Given this list of marker genes TP73, HMGB1, BCL2L11, DSG3, MAPK3, FADD, MAPT, PSMA7, LMNA, PSMD13, BAD, PSMB4, KPNA1, DIABLO, AKT3, ACIN1, UBC, BID, PSMB3, APPL1, CASP9, PSMB7, DAPK3 (NCBI Gene Id 1613), CFLAR, TP53BP2, DYNLL2, DCC (NCBI Gene Id 1630), GAS2, BCL2 (BCL2 apoptosis regulator), PSMD8, CYCS, APAF1, PSMD1, SATB1, PSMA3, TNFSF10, RIPK1, TICAM2, STAT3, PSMB5, XIAP, STK24, DFFA, SFN, PLEC, H1-3, PAK2, PKP1, PSMD14, CTNNB1, GSDMD, YWHAH, BBC3, PSMD2, CASP8, SPTAN1, H1-4, DSG1, NMT1, ORF71, MC159L, PSMD11, MAPK1 (NCBI Gene Id 5594), BCAP31, TRADD, LY96, TJP1, PSMB6 (NCBI Gene Id 95505), C1QBP, TRAF2, ADRM1, MAPK8, PTK2, OPA1 (OPA1 mitochondrial dynamin like GTPase), AKT1, PSMC4, BIRC2, PSMA1, KPNB1, RPS27A, DSP, PPP3CC, DFFB (DNA fragmentation factor subunit beta), ADD1, YWHAZ, PSMC1, ARHGAP10, PPP1R13B, FNTA, H1-1, CDKN2A, TNFRSF10B (TNF receptor superfamily member 10b), PSMA2, PSMC5, GSN (gelsolin), PSMD6, DNM1L, APC, YWHAQ, FAS, E2F1, PSMA4, CARD8, PSMD3, UNC5A, PSMB2, TP53, PSMD12, TNFRSF10A (NCBI Gene Id 8797), CD14, SEPTIN4, PRKCD, TICAM1, TLR4, TFDP1, STK26, APIP, CASP6, HMGB2, SEM1, PSMC2, DYNLL1, BCL2L1, PSMA5, UBB (NCBI Gene Id 91253), BAK1, MAGED1, YWHAG, PSMC6, UACA, ROCK1, CASP3, PSMB1, DAPK1, H1-0, PSMD7, FASLG (Fas ligand), DAPK2 (NCBI Gene Id 23604), CASP7, TFDP2, OMA1, GSDME, DSG2, PSMA6, DBNL, UBA52, OCLN, AVEN, UNC5B, VIM, TP63 (tumor protein p63), AKT2, PPP3R1, BAX, CLSPN, LMNB1, TJP2 (NCBI Gene Id 9414), BMF, H1-5, PMAIP1, GZMB, BMX, H1-2, PRKCQ, YWHAB, PSMC3, YWHAE, CDH1, here is a description of the gene set: Apoptosis is a distinct form of cell death that is functionally and morphologically different from necrosis. Nuclear chromatin condensation, cytoplasmic shrinking, dilated endoplasmic reticulum, and membrane blebbing characterize apoptosis in general. Mitochondria remain morphologically unchanged. In 1972 Kerr et al introduced the concept of apoptosis as a distinct form of "cell-death", and the mechanisms of various apoptotic pathways are still being revealed today. <BR>The two principal pathways of apoptosis are (1) the Bcl-2 inhibitable or intrinsic pathway induced by various forms of stress like intracellular damage, developmental cues, and external stimuli and (2) the caspase 8/10 dependent or extrinsic pathway initiated by the engagement of death receptors<BR> The caspase 8/10 dependent or extrinsic pathway is a death receptor mediated mechanism that results in the activation of caspase-8 and caspase-10. Activation of death receptors like Fas/CD95, TNFR1, and the TRAIL receptor is promoted by the TNF family of ligands including FASL (APO1L OR CD95L), TNF, LT-alpha, LT-beta, CD40L, LIGHT, RANKL, BLYS/BAFF, and APO2L/TRAIL. These ligands are released in response to microbial infection, or as part of the cellular, humoral immunity responses during the formation of lymphoid organs, activation of dendritic cells, stimulation or survival of T, B, and natural killer (NK) cells, cytotoxic response to viral infection or oncogenic transformation. <BR> The Bcl-2 inhibitable or intrinsic pathway of apoptosis is a stress-inducible process, and acts through the activation of caspase-9 via Apaf-1 and cytochrome c. The rupture of the mitochondrial membrane, a rapid process involving some of the Bcl-2 family proteins, releases these molecules into the cytoplasm. Examples of cellular processes that may induce the intrinsic pathway in response to various damage signals include: auto reactivity in lymphocytes, cytokine deprivation, calcium flux or cellular damage by cytotoxic drugs like taxol, deprivation of nutrients like glucose and growth factors like EGF, anoikis, transactivation of target genes by tumor suppressors including p53.<BR> In many non-immune cells, death signals initiated by the extrinsic pathway are amplified by connections to the intrinsic pathway. The connecting link appears to be the truncated BID (tBID) protein a proteolytic cleavage product mediated by caspase-8 or other enzymes. species: Homo sapiens part of: Programmed Cell Death Reactome Pathway: Apoptosis